Given this list of marker genes PSD, CCK, KRT6A, GAS8, LRIT1, MTA2, SEMA7A, PLIN1, SIX3 (SIX homeobox 3), GIP, GPR17, KCNN1, GNG7, ADRA1D, ACSL6, SEZ6L, PDE4C, REN, SIX6, IL3, CEACAM4, PAX6, PARD3, TAGLN3, DMBT1, CNKSR1, NRXN1, PHF20, S100A5, MPZL2, LCE2B, SSTR2, CXCL5, RASL10A, ASIP, NTRK1, UNC119B, ADGRL3, ALOX15, VCY, GALNS, PDCD1, UCN, MLANA, MET, GNG4, ATP6V1G2, PAX4, GAGE12G, SERPINA4, MYOG, PKP3, SHBG, APC2, HLA-DOB, MAGI1, HOXD10, SLC18A1 (NCBI Gene Id 6570), CEACAM3, PGC, TNFRSF10D, CHRNB1, FAM131B, HCRT, B3GNT3, CALB2, ACTL6B, VAMP1, EIF4EBP1 (eukaryotic translation initiation factor 4E binding protein 1), THRA, FUT3, MYCL, HTRA2, RANBP9, TBR1, TEX28, REG1A, HOXB1, COL10A1, GBF1, CDK5R2, S100A4, IVL, FCN2, CHP2, PIGL, RHBDL1, SCYL3, MYEF2, CYP27B1, ZBTB24, ABCA1, PTPRN, REPS2, MAPK13, TNFRSF21, NMB, AANAT, ARFGAP3, ANKRD26, TACC2, CRCP, GRK3, NSG1, LYPD3, KIAA0586, BARX2, LRCH4, TBXT, CSH2, INTS9, L1CAM, AKAP3, DNAH9, ANPEP, CYP2E1, NEMF, PAX7, RGS9, SLC22A6, ADAM20, REG1B, FLT1 (fms related receptor tyrosine kinase 1), CFAP410, MTHFR, CHST3, LORICRIN, PPP6R2, COL19A1, SLC7A11, CCL16, LY6G6C, TNFRSF6B, RUNDC3A, PZP, ECE2, ZNF143, BRD4, HOXD13, SNAP25, TFAP2B (NCBI Gene Id 7021), HRK, GRK1 (G protein-coupled receptor kinase 1), DHRS2, CD3E, KCNQ3, SMAGP, MYOZ3, ITIH1, IKBKG, EXOSC2, KCTD17, NECTIN1, DNALI1, CD86, FZR1 (NCBI Gene Id 8855), KCND3, SZT2, SLC17A3, SLC17A7, KRT33B, CCL7, HTR4, MLC1, CCDC9, CCKAR, EIF1AY, CELA2B, ING1 (NCBI Gene Id 3621), CDH1, DKK4, RAC2, RIBC2, ATOSB, MSI1, MAGEC1, ARID1A, KRT2, TRIB1, S1PR2, CDA, GTSE1 (G2 and S-phase expressed 1), BRME1, PPP3CA, GPR3, SSX4, HOXC11, HMHB1, CEP135, CSTF2, ZNF157, TRIM10, TAOK2, GALR3, RCVRN, MYH2, CHRNB4, KIF21B, KRT32, NDRG2, SOX10, EPOR, ASIC3 (NCBI Gene Id 9311), STATH, EMID1, TP63 (NCBI Gene Id 8860), MLLT1, HBB, TNFRSF10C, AMMECR1, JAKMIP1, SLPI, POM121L9P, MPZ, AOC1, PGAM2, DEFA1, CCNF, TBX1, PRF1, PIK3IP1, CBLN1, PSCA, AMELX, NRG2, NR2E3, PRB4, H3C6, CYP2F1, ADRA2C, NELFA, LILRA4, GNMT, MAGEA4, AQP8, AKAP7, CBL, PTP4A3, MPO, ENTPD2, CTAG1B, CNTN6, SPART, GRIK5, SLC7A4, SYT5, FEV, NNAT, KRT85, ADA, WNT10B, QPCT, EDA, CTSG, PRG2, SCN2B, ACR, BRMS1, ALDOB, TNFRSF13B, CYP2C19, NAT8, PPP4R2, GFPT2, HSD17B1, WASF2, ATP4A, HAAO, SIT1 (NCBI Gene Id 27240), EXD2 (NCBI Gene Id 55218), CDH16, SLC22A18AS, FAT2, KIF1C, ZP2, CCHCR1, SFTPC, GRM2, DIDO1, SCGN, HPR, RAP2C, GLE1, CD8A, HAP1, PROC, NR0B2, GREM1, FAM13A (NCBI Gene Id 389211), SLC29A2, CD4, RBMXL2, ZC3H14, FMO5, BMP10, H6PD (NCBI Gene Id 9563), ABCB9, NCALD, SPINK2, TNNT1, CLDN5, SPC25, ELAVL2, CASP2, DTNB, MAT1A, CD33, FANCL, ISG20L2, MACIR (NCBI Gene Id 90355), RAC3, SLIT3, SYNGR4, TYR, ABCC8, GHITM, SRPK3, RAD51D, PRSS16, PI3, PRELID3A, MAGEA9, RRH (NCBI Gene Id 10692), KRT13, PPT2, DNAJB12, EPM2A, ODF1, NTNG1, PNOC, PIGO, DNASE1, PSG7, RECQL5, TRIM15, TRPM2, CLDN14, FKBP6, S1PR4, PTH2R, RPH3A, CD82, INHBC, PDE4A, CYP2A7, SLC6A2, RIMS2, CHST1, CLDN9, TMSB4Y, LEFTY1, RCE1, COL2A1, here is a description of the gene set: Genes in the cancer module 104. Human Gene Set: MODULE_104 species: Homo sapiens